Given this list of marker genes Smad3, Bcl9, Ctnnbip1, Nherf1, Cxadr, Tcf7l2, Sufu, Gja6, Ruvbl2, Cdh20, Hdac6, Med12l, Pin1, Cdhr18, Setd1a, Ctnnd2, Gsk3b, Cdh22, Trem2, Vinac1, Cdh23, Cdh10, Amer2, Cdh11, Kank1, Trpc4, Nos2, Cdh9 (NCBI Gene Id 12565), Dchs1, Sox30, Prkn, Cdh3, Cdh18, Nos3, Prmt2, Klf4, Cdhr5 (NCBI Gene Id 72040), Axin2, Ash2l, Tcf4, Foxo4, Cdh2, Bcl9l, Dvl1, Lzic, Apc, Cdh17, Sall1, Med12, Smad7, Cdh8, Gja1, Tbl1xr1, Cdh1, Nf2, Dvl3, Ctnna2, Ep300, Cdh24, Tjp1, Nherf2, Apc2, Kdm6b, Cdh13, Cby1, Met, Sox9, Pxn, Adnp, Psen1, Tcf7, Ar, Ptpru, Ptprj, Amer3, Rora, Vcl, Cdh6, Ptprk, Cd2ap, Cdh5, Calcoco1, Esr1, Pin1rt1, Specc1l, Axin1 (axin 1), Sox17, Gli3, Foxo3, Skp1, Cdh7, Prop1, Chd8, Cdh19, Amer1, Tax1bp3, Btrc, Cdh4, Ptprt, Cdh15, Ctnna3, Csnk2a1, Grin2b, Dlg5, Tcf7l1, Cdh26, Cdh12, Ctnna1, Ctnnd1, Dact2, Ajap1, Lef1, Foxo1, Dact1, Shroom2, Numb, Rnf220, here is a description of the gene set: Binding to a catenin beta subunit. species: Mus musculus Mouse Gene Set: GOMF_BETA_CATENIN_BINDING